The following is a description of a gene set: Genes predicted to be targets of miRBase v22 microRNA mmu_miR_7006_5p in miRDB v6.0 with MirTarget v4 prediction scores > 80 (high confidence targets). species: Mus musculus from publication Chen Y, Wang X (PMID 31504780) Mouse Gene Set: MIR_7006_5P, and this is the list of marker genes: Pja2, Egln3, Ctsb, Fxr2 (NCBI Gene Id 23879), Zfp512b, Gng4, BC004004, Ptpru (NCBI Gene Id 19282), Mmp15, Ascl1, Iqsec2, Setd1b, Phf8, Slc7a1, Col5a3, Agpat1, Igfbp5, Cnih4, Srgn, Ctdsp1, 4933428G20Rik, Sgsm1, Thpo, Grap2, Crhr2, Pgbd5, Tpcn1, Zc3h7b, Fam222a, Nav2, Cdc42se1, Ifnar2, Kndc1, Rab11fip1, Scn4a, Kmt2d, Ildr2, Ryr1, Ywhah, Castor2, Kmt5a, Fam187b, Rab3a, Zswim4, Tfeb, Hrk, Smarcc2, Gprc5b, Alox5, Ablim3 (actin binding LIM protein family, member 3), Cyp24a1, Snn, Parvb, Anxa13, Ddx19a, Sim2, Xirp1, Nwd1, Cacna1c, Pou2f2, Cdh5, Prkag3, P2rx1, Rcan1, Vamp2, Tfap2b, B3gnt7, Git1, Stk39, Ctnnbl1, Lelp1, Prkcg, Palm, Kpnb1, Celf5, Metap1, Erf, Tmem104, Nectin1, Snap25, Ptpn14, Cdk5r2, Sox4, Rgma, Mapre3, Mknk2, Fgfr1, Efna5, Gpx3 (NCBI Gene Id 14778), Asap2, Cited2, Yrdc, Pgap3, Padi2, Tmem132a, Gnrhr, Dagla (NCBI Gene Id 269060), Fer, Sorbs3 (NCBI Gene Id 26990), Gigyf2, Fosb, Rab1b (RAB1B, member RAS oncogene family, NCBI Gene Id 76308), Tmod2, Tpgs2, Tbkbp1, Fbxl19, Vwa3a, Ttc9, Sod3, Kalrn, Engase, Timm17b, Eif5a, Phox2b, Kifc2 (kinesin family member C2), Cpeb1, Phospho1, P2ry6, Zfp362 (zinc finger protein 362), Tnfaip8l2, Tmem86a, Cxcr4, Foxp4, Pip5k1a, Zbtb39, Nlrp10, Kcnk3, Gas7, Gpr3, Nrn1, Igf2, Spry4, Zfp687, Src